The following is a description of a gene set: studied in species Homo sapiens Binding to a mismatch repair complex. Human Gene Set: GOMF_MISMATCH_REPAIR_COMPLEX_BINDING, and this is the list of marker genes: MSH2, MSH6, PCNA (NCBI Gene Id 5111), WRN (NCBI Gene Id 7486), TREX1, MLH1, PMS2, MCM8, MCM9 (minichromosome maintenance 9 homologous recombination repair factor), MUTYH, ATR